The following is a description of a gene set: from publication Chen Y, Wang X (PMID 31504780) Human Gene Set: MIR181A_3P Genes predicted to be targets of miRBase v22 microRNA hsa-miR-181a-3p in miRDB v6.0 with MirTarget v4 prediction scores > 80 (high confidence targets). species: Homo sapiens, and this is the list of marker genes: SHQ1, MAP3K5, NPAS4, AGK, TNRC6C, BTC, RGS3